The following is a description of a gene set: studied in species Mus musculus Mouse Gene Set: GOCC_CYTOPLASMIC_REGION Any (proper) part of the cytoplasm of a single cell of sufficient size to still be considered cytoplasm., and this is the list of marker genes: Tssk6, Spmip11, Dnah17, Madd, Hnrnpa2b1, Brwd1, Atg5, Ift57, Tektip1, Dnali1, Ctbp1, Neto1, Efcab6, Dnah7a, Odad1, Bloc1s4 (NCBI Gene Id 70328), Dnah9, Rims2, Ssna1, Dnah5, Cfap276, Bbs1, Map2, Clxn, Rpgrip1, Pttg1, Kif1a, Kif5b, Hnrnpab, Rsph6a, Kif3a, Pclo, Septin9, Spef1, Ttll10, Cimip2c, Kif17, Sod1, Lrrc51, Dynll1 (dynein light chain LC8-type 1), Cfap44, Rp1, Hamp2, Nlrp5, Odad4, Spata4, Kif3b, Clasp1, Rimbp2, Ribc1, Cfap107, Atg7, Wdpcp, Dync1i1, Lrrk2, Rsph14, Odad3, Gnat3, Dnai4, Trim46, Abhd12, Tuba1a, Dnah2, Ap3m2, Kifap3, Nek4, Tchp, Clasp2, Armcx3, Prkar2a, Arl8b (NCBI Gene Id 69275), Dst, Rab21, Dynlt2b, Arl13b, Tekt2, Map1lc3b, Bloc1s6, Insc, Dnal1, Cep162, Cfap100, Lca5l, Akr1b1, Spef1l, Tubb4a, Odad2, Phldb2, Agbl4, Spmip9 (NCBI Gene Id 74221), Cfap141 (NCBI Gene Id 73545), Cfap221, Rab17, Wls, Septin2, Fmr1, Bloc1s1 (biogenesis of lysosomal organelles complex-1, subunit 1), Atg14, Tekt3, Ccdc65, Erc2 (ELKS/RAB6-interacting/CAST family member 2), Ap3b1, Efhb, Kif5a, Dnai2, Gabarapl1, Mgarp, Cfap206, Tekt1, Iqsec2, Tmem108, Dtnbp1 (dystrobrevin binding protein 1), Hamp, Nme7, Arfgef2, Hsbp1, Hydin, Hspb1, Spmip8, Cimip2a (NCBI Gene Id 68222), Ambra1, Cfap73, Rsph3b, Phldb1, Spast, Camsap3, Dydc1, Ak8, Ap3b2, Ctbp2, Tulp3, Inpp5e (inositol polyphosphate-5-phosphatase E), Togaram1, Cfap144, Cfap210, Cys1, Nr3c2, Dnai3, Kif19a, Dzip1l, Spag8, Dync1i2, Bsn, Spg7, Rpgrip1l, Abhd13, Gas8, Ctnnd1, Dnhd1, Cdkl5, Cfap36, Cfap69, Pacrg, Wdr35, Pafah1b1, Camk2a, Ift140, Dusp21, Mak, Bbs7, Cfap53, Ift70b, Canx (NCBI Gene Id 66219), Dnai1, Kif21a, Pik3r4, Cfap70, Gck, Ropn1l, Arl8a, Bloc1s3, Ap3s2, Traf3ip1, Gli1, Zc3h14 (zinc finger CCCH type containing 14), Dctn1, Cfap119 (NCBI Gene Id 233899), Spag17, Map2k4, Caly, Ap3m1, Cfap61, Sptbn5, Gli2, Septin7, Gli3, Dnajb13 (NCBI Gene Id 69387), Map1a, Mapk8, Hip1r, Spag6, Spmip6, Dnai7, Saxo1, Pkd2, Spag6l, Chrna2, Arl6, Nme5, Dnah10, Atg16l1, Ap3d1, Dnaaf1, Bloc1s2, Rab27b (NCBI Gene Id 80718), Hpca, Ccdc96, Stxbp1, Tekt5, Dusp3, Saxo2, Ift70a2, Oprm1, Lca5, Bbof1, Gabarap, Dnah3, Snapin, Dync2h1, Tekt4, Cfap45, Spaca9, Prkar1a, Kcnab1 (NCBI Gene Id 16497), Rsph9, Ada, Rp1l1, Ift70a1, Dlg2, Cfap74, Tektl1, Ribc2, Pqbp1, Mapt, Fabp2, Cfap126, Ppfia3, Htt, Sapcd2, Akap14, Cntf, Ttll8, Ccdc39, Iqub, Rsph3a, Hap1, Dnah7c, Dnah11, Cfap91, Cfap68, Pierce2, Rims3, Agtpbp1, Hdac6, Uchl1, Baiap2, Ift172, Rsph4a, Wdr11, Gpsm2, Cfap77, Map2k1, Cfap95, Ctnnb1, Ap3s1, Flot2, Ctsh, Dnah6, Cfap161, Mark2, Kif3c, Grik3, Prkcz, Ccdc63, Cfap20, Dync2li1, Spmip10, Ccdc40, Numa1, Dcdc2a (NCBI Gene Id 195208), Rangap1, Sybu, Enkur (NCBI Gene Id 99177), Uhmk1, Dnah12, Spmip5 (NCBI Gene Id 67507), Dnah7b, Cenpf, Stau2, Ttll3, Kif21b, Cfap90, Arl3, Ccdc113, Dnah8, Arc, Dlg4, Tmem67, Mapk8ip3, Ccdc66, Unc13a, Cfap54, Ccdc103, Efhc2, Mns1, Spata7, Ift88, Ndel1, Spag16, Eif4ebp2, Kif5c, Ctnna2, Myo5b, Grik2 (NCBI Gene Id 320644), Saxo4, Gucy1b1, Cimip2b, Dync2i2 (dynein 2 intermediate chain 2), Erc1, Ckap5, Gria2 (NCBI Gene Id 14800), Tubb4b, Dnah1, Rims1, Nme8, Rsph1, Drc3, Hif1a (hypoxia inducible factor 1, alpha subunit), Klhl17, Dynlt4, Cfap52, Ccsap, Drc1, Fabp1, Prkaca, Nefl, Cfap43 (NCBI Gene Id 74924), Mapk1, Efhc1, Osbpl2, Pierce1, Ranbp1, Bbs5, Bloc1s5, Kif1b